The following is a description of a gene set: Cell cycle arrest in response to DNA damage is an important antitumorigenic mechanism. MicroRNAs (miRNAs) were recently shown to play key regulatory roles in cell cycle progression. For example, miR-34a is induced in response to p53 activation and mediates G(1) arrest by down-regulating multiple cell cycle-related transcripts. Here we show that genotoxic stress promotes the p53-dependent up-regulation of the homologous miRNAs miR-192 and miR-215. Like miR-34a, activation of miR-192/215 induces cell cycle arrest, suggesting that multiple miRNA families operate in the p53 network. Furthermore, we define a downstream gene expression signature for miR-192/215 expression, which includes a number of transcripts that regulate G(1) and G(2) checkpoints. Of these transcripts, 18 transcripts are direct targets of miR-192/215, and the observed cell cycle arrest likely results from a cooperative effect among the modulations of these genes by the miRNAs. Our results showing a role for miR-192/215 in cell proliferation combined with recent observations that these miRNAs are underexpressed in primary cancers support the idea that miR-192 and miR-215 function as tumor suppressors. studied in species Homo sapiens Genes down-regulated in HCT116 cells (colon cancer) by expression of MIR192 or MIR215 at 24 h. from publication Georges SA, Biery MC, Kim SY, Schelter JM, Guo J, Chang AN, Jackson AL, Carleton MO, Linsley PS, Cleary MA, Chau BN (PMID 19074876) Human Gene Set: GEORGES_TARGETS_OF_MIR192_AND_MIR215, and this is the list of marker genes: ACSL1, KPNA5, BCL2L13 (NCBI Gene Id 25779), HADH, OSBPL6, KCNMB4, MMP20, ICAM3, USP12, WWC2, STIL, IRX4, NLK, ORC1, PLK4, RAB6C, HASPIN, NRG4, DDX3X, CCDC174, BCORL1, PPP1R18, TMTC4, ANLN, ZNF248, COBLL1 (cordon-bleu WH2 repeat protein like 1), FAIM, TOPBP1, ASRGL1, NDE1, LMNB1, SLC16A14, GPSM2, FEN1, TRIM59, POLQ, ST3GAL6, KLHL15, KIF18A, UBIAD1, UBE2D2, PGM3, STK3, PXDN, SLC39A8, RP9P, CUZD1, CMPK2, DENND11, HOXB9, HBEGF, ROPN1L, ARL4C, ATRNL1 (attractin like 1), CFL2, PRRC1, TMEM169, FADS1, N4BP2, MIB1, ERMP1 (NCBI Gene Id 79956), TARDBP, ATF1, NOL12, CCDC121, PRADC1, OVOL1 (ovo like transcriptional repressor 1), CLN6, FZD1, TMTC2, CHST12, BARD1, LARP1B, ZNF320, FAM20B, SP4, RDM1, LIN9, STOX2, DHCR24, ARHGEF10, GABPB2, FUT11, ZNF85, SEC23B, PALS1, EMC7, DDHD1, NPTXR, DNAJB4, ZMYND11, PPP2R3B, MCM10, CDCA4, UACA, ZNF652, ZNF200, ASPH, FBXO25, ANKRD6, CLK4, CA13, FAM199X, CHM, AGO2, PAFAH1B1, GAS2L3, FZD4, CDK14, RAD21, DEPDC1, BLM, ZNF346, RFC4, MRPL43, UBE2W, CENPA, UPP1, LRRFIP2, ACTR1B, SLF1, ZIC5 (Zic family member 5), KIF20A (NCBI Gene Id 94421), PERP, FAM171B, KDM4D, NSF, ATP6V1G1, PIF1, BMAL2, SERAC1, CEP43, VPS13C, BLTP3A, NPNT, SCRN3, GINM1, GNAS, IFRD1, CNEP1R1, TROAP, CKLF, KIFC1, HAS3, DLGAP5, ZSWIM3, ERCC6L, PASK, NEK1 (NCBI Gene Id 51037), KLHL23, ARHGAP29, THBD, CHD7, ZNF385B, ANG, BCL2, C6orf62, HES6, NAA20, CCNO, KIF5B, ATAD2, SNX10, G2E3, AGPAT5, LAMTOR5, PAK6, CMTM6, NCEH1, SASS6, DEAF1, GCH1, MED22, IMPA1, SAYSD1, SOAT1, APOLD1, MOAP1, HNF1B, EPS8, KIF15, LRP8, TBC1D31, ZDHHC2 (NCBI Gene Id 51201), CNTNAP3, SLC25A30, PURA, ATAD1, SCD, RNF26, ZNF273, FKBP15, EXTL2, CHPT1, TCHP, CCDC14 (coiled-coil domain containing 14), TNFSF13B, OSBPL8, RAP1GAP, B3GALNT1, ZNF525, NT5M, PRIM1, PXDC1, IL15, AKAP11, ATAD5, NREP, NFIB, NUCB2, TMTC3, MSN, CCDC18 (NCBI Gene Id 343099), ZNF267, TCF7, ERCC3, POLA2, ENDOD1, MINDY2, MTMR12, ZBTB6, IL17RB, MT1F, RAB3B, RAB1A, ELOVL5, XK, KIF14, SGCB, WWC3, WDR76, POGLUT3, SPATA13, PGAP4, ZNF184, SNX13, DDX50, TOR1B, TRIM68, CHDH, ALDH5A1, CENPK, C21orf91 (NCBI Gene Id 89755), MTSS1, PPM1A, FGF2, BBOF1, ENC1, BTC (betacellulin), FIRRM, COPS7A, BRCA2, HERC2, PHTF2 (NCBI Gene Id 57832), PRRG4, PABPC4, MRTFB, ESCO2, MAP1LC3B, RCBTB2, ID1, SAMD13, CIB2, DCP1A, KCNS3 (potassium voltage-gated channel modifier subfamily S member 3), CUL5, DLG5, LMNB2, SH2B3, FANCM, ABCB10, HSPA2, CCDC47, PRKD3, MCM3, CAB39L, BORA, AFAP1L1, PRPF38A, FBN1, PPARG, NUFIP1, CTNNBIP1, MTRFR, GRK3, MCM9, PRKAA2, KIF5C, ACVR2B, ZNF823, RACGAP1P1, THOP1 (NCBI Gene Id 92731), LYRM7, LIPA, TMED10, INPP5F, EPM2A, USP34, NSD2, EMC1, PRPS2, TPGS2, LYPD6, TDG, SARAF, CTH, ANKRD13A, GPR180, RASSF8, LEPROTL1, ANAPC15, MFSD13A, DNAJC3, SLC35F3, HMMR, BICD1, CDKN2A, WDCP, RAB27A, LSM14B, EME1, C9orf163, ZMAT3, ZBTB34, EPDR1, METTL9, CDC7, LHFPL6, MT1X, GALNT12, TUBGCP3, RBP7, CENPE, LIMCH1, CAMK4, DNAJC19, KNL1, NUCKS1, NAB1, NEDD1, EGR1, MTERF3, GNRH1, CYP24A1 (cytochrome P450 family 24 subfamily A member 1), NKX3-1 (NCBI Gene Id 4824), PRNP, C1orf53, MCM6, IRAK1, CYP4V2, TRAIP, ZDHHC23, DSTYK, ALCAM, MKI67, ELOVL1, OSBPL10 (oxysterol binding protein like 10), GID8, FBXW2, GATAD1, TRIB3, RFLNB, RNF6, TTK, DENND1A, FAM111B, STAMBPL1, RFWD3, FAM110C, PITPNB, TMEM106A, BCOR, NIPAL1, ZXDC, SYNGR1, LGMN, RTKN2, SRD5A1, ZNF701, SBDSP1, PSMD6, ID2, FAM241A, MIS18BP1, HAUS3, HYCC2 (hyccin PI4KA lipid kinase complex subunit 2), CDON, TMEM30A, GPANK1, CLIP4, CLVS1, ENTREP1, MRPL13, B3GNT5, NCAPH, SLC7A11, TEX30, AHSA2P, COCH, TPM4 (NCBI Gene Id 7171), USP54, NFKBIZ, TRPV1, E2F8, ALG10B, MOSMO, ZNF45, NBN (nibrin), CCZ1B, HYCC1, HOXA10, NEIL3, PIP4K2B, CDC14A, SLCO3A1, USP45, RB1, TDP1, EOGT, ZNF215, CENPF, GPR137C, SIX4, SERTAD4, LRRC58, EMB, NOD2, ZFYVE28, RNF141, SYNCRIP, SLC35G1, BIVM, RIC8B, GPR37, UCK1, STK17B, FOS, PKP4, BMPR2, IL1R1, CD164, APC, MDM4, SANBR, FLVCR1, DNAJB9, NOXO1, ARHGAP19 (Rho GTPase activating protein 19), GATB, BBS7, SCMH1, RIMKLA, HYLS1, CHML, CADPS2, INIP, DEGS1 (NCBI Gene Id 8560), PIM1, MACF1, CCZ1, COQ3, C2orf49, RECQL, TMPO, NOB1, UBASH3B, MDC1, ZNHIT3, JADE1 (NCBI Gene Id 79960), DHFR2, RACGAP1, ITGB1, C18orf54, KIF20B, GULP1, IL1RAP, LRRFIP1, ZFP30, SPTBN1, AASDHPPT, MSRB3, ZFP1, SGPP1, AP3M2, C16orf46, RAD54B, MNS1, CEP78, RSBN1, BTNL9, DCBLD2, SATB2, RMI1, KLF10, EHBP1L1, CMPK1, CORO2B, TMEM200B, TMEM164, FBXO3, HCN4, RSBN1L, MZT1, CD83, DIS3L, SLC25A51, RSRC1, PODXL, ARL6IP1, LARS1, MAN2A2, EDRF1, PMF1, BTF3L4, CA8, ZNF443, TOR3A, AMMECR1, KIF24, NSD3, SLC25A40, PDLIM3, CRLF3, RPAP3, PPP1CA, PLAGL2, SLC35B4, ZNF704, STAM, SLC1A4, STXBP4, MAPK9, MACIR, GRHL1, RAB40B, PHF19, CILK1, FAM120AOS, ARL2BP, CCNY, ADGRG6, SMC2, SAMD3, ALDH9A1, BMP2K, PSRC1, SGMS2, SLC16A6, MAD2L1 (NCBI Gene Id 4085), TMC3, SEMA4D, SMARCA2, IL7, PPP1CB, DTL, NCBP1, SKA1, EFNB2, CDKN2D, CLK1, MAP6D1, SH3BP4, CCDC7, ZBTB18 (zinc finger and BTB domain containing 18), IGF1R, FANCI, CDC25A, CHSY3, HMGCS1, UBL3, CLSTN1, NKRF, TENT4A, EEA1 (NCBI Gene Id 8411), MIS12, NEMP1, MRPL50, TBC1D22B, SPRY4, TMEM17, SMARCB1, ZBTB33, ACVR2A, GAREM2, SAP30, HSPBAP1 (HSPB1 associated protein 1), FHDC1, ERICH5, NHSL1, KCTD12, FBXO31, CEMIP2, LRRC8C, OPA1, PCDH7, REEP1, ZNF230, APPL1, TMEM200A, XIAP, AP1S2, AGL, ATP5MG, SEC24D, OTUB2, PPP1R12A, UBE2V2, DIMT1, TOP1, PPAT, UVRAG, GLCCI1, CKAP4, PCSK9, ERFE, GAB2, ZC3H12C, EIF2AK3, PARN, MCAM, FBXO5, DGCR11, ZNF114, STX7, DEK, MPZL1, PLEKHF2, RHOBTB3 (Rho related BTB domain containing 3), VGLL3, ZNF165, LMAN1, RAB23, DUSP16, POU2F1, GATM, TOP1P1, DNAL1, IQGAP1, RUFY3, NDFIP2, HOOK3, FAM241B, FERMT1, ZNF611, FAAP20, CDC20, CGNL1, TENT4B, PRSS23, TMEM170B, PRKAR1A, HCN3, PTGR3, CTPS2, FOXA1, USP18, CERS6, KBTBD11 (kelch repeat and BTB domain containing 11), RAB11FIP2, NAA50 (NCBI Gene Id 80218), SPCS3, INSIG1, MEIS2, TJP2, RAD1, FAXC, TFCP2L1, SOWAHC, EPM2AIP1, PPP1R26, TRIM23, NPHP3, GEN1, OBI1, PIGX, ENTPD7, VANGL1, SLC46A3, FNBP1, SENP1, ASPM, BUB1B, SPAG9, UBE2D1 (NCBI Gene Id 9335), CRK, MEX3B, ALG10, PLOD1 (procollagen-lysine,2-oxoglutarate 5-dioxygenase 1), TAF9B (NCBI Gene Id 51616), C17orf58, ERCC6, KLHL8, PTBP2, PLCE1, UQCRC2, SLC9A5, NFYA, EEF1A2, CASP7, KCTD15, IFNLR1, PHTF1, CEP55, ZNF449, ZBTB14, NIN, NIPA1, UNG, OTUD1, TOR1AIP1, DST, CLSPN, KRT18P8, PRICKLE1, PRDM4, TRAF3IP3, ZNF641, LEAP2, ERCC4, SNRPD1, PPP2R2D, ELOCP3, RADX, TTPA, ATG10, CCSAP, TCFL5, ZNF226, EAF1, RNPC3, XPO1, THEM6, OTUD3, TMEFF1, HESX1, PTS, CCNE1, NMI, ELL2, ELOA, OGFRL1, MSH6, ZBTB10, RPGRIP1L, SLC19A2, KIAA1143, CENPI, RAB8B, PAWR, SLF2, BICRAL, PIGM, SAMHD1, PRIMPOL, CREBZF, BRCA1, ANO6, TRPC1, PARP16, LRIG1, PHF10, DBT, ANAPC10, BRIP1, ARFGEF1, WNT3, UGT8, CKAP2L, RNASEL, FBXO36, NCOA3, KLHL42, PANX1, HACD3, RAB2A, TNFSF12, ATG4A, L2HGDH, PLEKHG2, SLC7A2, C1orf198, SLC16A7, VXN, FUBP1, AKAP7, HIBADH, LRRCC1, ZMYM1, ACTR2, FZD7, SLC39A1, GPR19, FNDC3B, PITPNC1, LYSMD3, SIRT1, PLAU (NCBI Gene Id 95176), FAM222A, NHLRC3, MIPOL1, GPC4, C1QTNF3, HS3ST3B1, NUF2, CDKN3, SEC63, ZNF780A, C5orf34, SMC4, TICRR, B4GALT6, NUDT15 (NCBI Gene Id 55270), TBL1X, MANF, ENPP4, IL6ST, TTF2, GARIN5A, PLS3, PHC2, ACADSB, RET, MYB, MELTF, CREBL2, KIF23, VASH2, KAT2B, RPS6KB1, HJURP, FAM83D, NMU, WDR47, LIMS1, DSN1, CPSF6, DICER1, USP1 (ubiquitin specific peptidase 1), PCGF5, CTCF, DNAJB5, ACSF3, DBF4B, LMLN, ZNF519, TRIP13, DYRK1A, CIT, IDI1, CEP19, TLCD5, EFCAB11, CCDC15, PSMC3IP, HOXA13, RPAP2, RNASE4, GFOD1, KHDRBS3, PTPRE, PHF6, CEP295 (NCBI Gene Id 85459), TCAM1P, EAF2, USP14, RAD51, MMAB, ECT2, EML1, SS18, SPIN4, KDM1B, SLC26A2, PCOLCE2, TICAM2 (TIR domain containing adaptor molecule 2), MXI1, CCL3L3, MFSD14B, HINT3, IRAK4, ARHGAP11A, SLC39A9, MBNL3, MTDH, FBXO4 (NCBI Gene Id 55087), SGO2, SFR1, IQCC, FOXD1, ITGAV, CEP128, KIAA1958